The following is a description of a gene set: Mouse Gene Set: SOX7_TARGET_GENES studied in species Mus musculus Genes containing one or more binding sites for (Sox7) in their promoter regions (TSS -1000,+100 bp) as identified by GTRD version 20.06 ChIP-seq harmonization. from publication Yevshin I, Sharipov R, Kolmykov S, Kondrakhin Y, Kolpakov F (PMID 30445619), and this is the list of marker genes: Notch4, Slc37a3, Fip1l1, Gm8357, mt-Cytb, Prokr1, Nmnat2, Ap2m1, Polr2a, 2610005L07Rik, G2e3, Gm5067, Arhgap24, Aloxe3, Ifnz, mt-Nd6, Zfp992, Abcg2, Rny3, H2bc6, mt-Nd2, Tc2n, Phc1, Aasdh, Vwf, Gm8379, Gins1, mt-Tp, Duxf1, Sfi1, Gm4793, Gm15564, Celf3, Midn, Gm3242, Ptma, Zfp36l1, Lrrn4, Clcn4, BB557941, Poldip3, mt-Tm, Gm11398, C920006O11Rik, Gm22417, Fbxo44, Gm12279, Celsr1, Arid2 (NCBI Gene Id 77044), Gm3084, Fubp1, Gnai2, Ighv1-67, Hexim1 (hexamethylene bis-acetamide inducible 1), Gm10222, Tex14, Etv6, Ndel1, Ubb, Fau-ps2, Gm11399, Alyref2, Mtf2, Rnf122, Myt1, Mir6236, Frat2, mt-Ti, Bcl2l11, Gtf3c6, Creb3l2, Gm37450, Smarca2, Gm26504, Gm43391 (predicted gene 43391), Tedc2, Fam124b, Zfp36l1-ps, Dnajb4, Ppp6r3, Vangl2, Zscan2, Ydjc, Hmgb1, 9030622O22Rik